Given this list of marker genes PLPP3, LRRC32, DPT, SAT1, CTSK, NAA10, DCT, CAPN5, PTK7, PAPPA, SELPLG, TMEM47, ELN, LHFPL2, PTGES, FN1, LSP1P5, FBXO32, NFASC, PER3, CRIP2, MAP1B (NCBI Gene Id 4131), ENO2, KRT34, PLOD2, ARL4C, PDPN, CCDC80, CELF2, LMCD1, ADAM12, LGALS3BP, ADM, CXCL1, AIMP2, ISLR, BLM, FNDC1, ARL4D, ELP5, CDON, LTBP2, SPECC1, HSPG2 (NCBI Gene Id 7796), LRRC15, MZT1, CREG1, SH3PXD2B (SH3 and PX domains 2B), SLC7A1, MDFI, VPS26B, CRIP1, SLIT3, ARHGAP5, CUL5, LRATD1, CPXM2, NNMT, MMP7 (NCBI Gene Id 4316), EGR1, AKR1C1, SDR42E1, EIF2B3, FAP, ITGB5, AKAP12 (A-kinase anchoring protein 12), CFB, VCAN, LAMA4, FMOD (fibromodulin), SLC43A3, ANTXR1, CCN1, here is a description of the gene set: species: Homo sapiens Reconstitution of telomerase activity by ectopic expression of telomerase reverse transcriptase (hTERT) results in an immortal phenotype in various types of normal human cells, including fibroblasts. Despite lack of transformation characteristics, it is unclear whether hTERT-immortalized cells are physiologically and biochemically the same as their normal counterparts. Here, we compared the gene expression profiles of normal and hTERT-immortalized fibroblasts by using a cDNA microarray containing 20,736 cDNA clones and identified 172 dysregulated genes or expressed sequence tags (ESTs). One of the highly expressed genes in the hTERT-immortalized fibroblasts (hTERT-BJ cells) encodes epiregulin, a potent growth factor. Blockade of epiregulin reduced the growth of hTERT-BJ cells and colony formation of hTERT-transformed fibroblasts. Moreover, inhibition of epiregulin function in immortal hTERT-BJ cells triggered a senescence program. Our results suggest that both activation of telomerase and subsequent induction of epiregulin are required for sustained cell proliferation. Given the significant difference in gene expression profiles between normal and hTERT-immortalized fibroblasts and the close relationship between epiregulin and tumorigenesis, we conclude that hTERT-immortalized cells may not replace their normal counterparts for studies of normal cell biology and that the use of hTERT for expansion of normal human cells for therapeutic purposes must be approached with caution. Genes down-regulated in BJ cells (foreskin fibroblasts) immortalized by expression of TERT. from publication Lindvall C, Hou M, Komurasaki T, Zheng C, Henriksson M, Sedivy JM, Björkholm M, Teh BT, Nordenskjöld M, Xu D (PMID 12702554) Human Gene Set: LINDVALL_IMMORTALIZED_BY_TERT_DN